Given this list of marker genes TERF2, STN1, PIF1, PARP1, TNKS, PINX1, TINF2, XRCC1, ACD, RAD50, SRC, GNL3L, SLX1B, TEN1, TENT4B, HNRNPC, HNRNPA1, NBN, RTEL1, SLX1A, ERCC4, XRN1, DCP2, TNKS2, ERCC1, SMG6, TERF2IP, NAT10, SLX4, HNRNPU, PML (PML nuclear body scaffold), CTC1, PARP3, TP53, TERF1, POT1, EXOSC10, MCRS1, ATM, here is a description of the gene set: Human Gene Set: GOBP_NEGATIVE_REGULATION_OF_TELOMERE_MAINTENANCE studied in species Homo sapiens Any process that stops, prevents, or reduces the frequency, rate or extent of a process that affects and monitors the activity of telomeric proteins and the length of telomeric DNA.